Given this list of marker genes Cox7a2l, Stk17b, Cybb, Tsc22d3, Shisa5, Btg2, Ptprc, Pirb, Arhgap9, Fth1, Eef2, Fos, Ms4a6b, Neat1, Itga4, Il13ra1, Smpdl3a, Ifitm3, here is a description of the gene set: studied in species Mus musculus Cytokines mediate cell-cell communication in the immune system and represent important therapeutic targets. A myriad of studies have highlighted their central role in immune function, yet we lack a global view of the cellular responses of each immune cell type to each cytokine. To address this gap, the authors created the Immune Dictionary, a compendium of single-cell transcriptomic profiles of more than 17 immune cell types in response to each of 86 cytokines (>1,400 cytokine-cell type combinations) in mouse lymph nodes in vivo. A cytokine-centric view of the dictionary revealed that most cytokines induce highly cell-type-specific responses. For example, the inflammatory cytokine interleukin-1β induces distinct gene programmes in almost every cell type. A cell-type-centric view of the dictionary identified more than 66 cytokine-driven cellular polarization states across immune cell types, including previously uncharacterized states such as an interleukin-18-induced polyfunctional natural killer cell state. Genes negatively differentially expressed in cell type: cDC2 (conventional dendritic cell type 2) upon treatment with cytokine: IL-4 in mouse lymph nodes in vivo. from publication Cui A, Huang T, Li S, Ma A, Pérez JL, Sander C, Keskin DB, Wu CJ, Fraenkel E, Hacohen N (PMID 38057668) Mouse Gene Set: CUI_CDC2_IL4_RESPONSE_DN